The following is a description of a gene set: Absence or underdevelopment of the clavicles (collar bones). Human Gene Set: HP_APLASIA_HYPOPLASIA_OF_THE_CLAVICLES species: Homo sapiens Aplasia/Hypoplasia of the clavicles, and this is the list of marker genes: B4GALT7, NSDHL, SALL4, HOXD13, RSPO2, RUNX2, LEMD2, CBFB, RNU12, CDC6, CTSK, SCARF2, FIG4, DCHS1, CDC42BPB, SRCAP, ZMPSTE24, FBXL3, KIAA0586, GMNN, CDC45, CHD4, FLNA, TRIP11, VAC14, ORC1, TWIST1, BCOR, WNT7A (NCBI Gene Id 7476), PTH1R, IDUA, MSX2, PIGL, TBX3 (T-box transcription factor 3), FAT4, BMPR1A, CDT1, NAA10, ALX4, DYNC2LI1, TBX5, ORC4, PTEN, XYLT1, FGFR2, ORC6 (NCBI Gene Id 23594), EFNB1, PTDSS1, LMNA, PORCN, BGN, RNU4ATAC, ATP7A